Given this list of marker genes ATP2B1, YPEL2, PLPP1, STING1, HIF1A, CNIH4, ISCU, LMNTD2, SNRNP70, CLINT1, LSM14A, SRCAP, ST6GALNAC2, CACNG4, FRYL, MYO1E, DGAT1, SLC43A1, ARID1B, ANGPTL2, GNB5, BRD9, FAM151B, CLEC4G, GRIN2B, CERS5, COX7A1, TAF8, ELL, MAP4K3, IGF1R, ZFR2, RGS1, ITGA4, GMIP, PLA2G3, ACAP2, MICALL1, BCL2A1, NOXRED1, ESYT2, C5orf34, SLAMF1 (NCBI Gene Id 6504), TNFRSF9, RASL11A (RAS like family 11 member A), ZNF362, FBLIM1, CCDC125, DDI2, ENTPD7, C19orf81, TNFRSF1B, SCLY, CDH7, GDNF, ITGB3, GAS8, SSBP3, RNPEPL1, ZBTB7B, NUCB2, PRNP, BIRC3, PPM1L, CORO2A, INPP4A, NEDD9, CTDSP2, PSEN2, PTTG1, FOXK2, FBXO6, IFI30 (IFI30 lysosomal thiol reductase), TMIGD1, TECPR1, BCR, CIR1, ECM1, TNFRSF25, FAM234B, SLC33A1, ITGAV, PGM5, CAPSL, GPX4, RAB37, WASF3, TMBIM4, EBI3, PADI4, LYZL6, CBLN3, PRDX5, IWS1, TSC22D1, ICOS, SLC12A6, PGGHG, KIFC1, PCDHB4, KDM2B, ADGRE5, ARPC2, STARD5, TIAM1, STMN1, MSL2, VPS54, ARHGAP31, SECISBP2L, NDST1, MTMR7, IDS, CCDC82 (NCBI Gene Id 79780), NID2, NRN1 (neuritin 1), EPHX4, RTN4, TNFRSF18, SUCO, THBD, ELP2, PHF3, HNRNPLL, TSPAN13, MFAP1, CWC15, C11orf96, SNX20, RAB22A, RBL2, CD6, DROSHA, MAP1LC3B, DND1, PRR13, CNTLN, TRIM46, CDKN2C, MLLT6, FERMT3, PLSCR1, SLC9A6, CPM, TEX2, C4BPA, CASP1, EXT1, NRDC, GTPBP2, IL17B, CDC25B, NHSL2, ATP11A, SPOP, NCK2, IBSP, CYSTM1, CPOX, ZDHHC15, CREBBP, SLC4A7, CHURC1, PLPP5, PTGER2 (prostaglandin E receptor 2), ZNF326, ODAM, DCAF11, SLC2A3, H1-0, DYNC1I2, KIAA0753, GAS2L1, TMEM191C, MYO5A, LRP10, ZNF462, APBA1, MKNK2, GXYLT1, RHBDF1, RAB2A, KCTD10, P2RX7, SON, FAAH, SZT2, WTAP, RNF19A, UROS, PISD, CASP4, ZMYND8, MAP2, CELA1 (NCBI Gene Id 1990), NEURL4, TMUB1 (transmembrane and ubiquitin like domain containing 1), GCA, CATSPERD, SSR1, here is a description of the gene set: Human Gene Set: GSE27786_CD4_VS_CD8_TCELL_UP species: Homo sapiens Genes up-regulated in comparison of CD4 T cells versus CD8 T cells. Each fraction of mouse hematopoietic cells was purified by cell sorting from bone marrow of 8-week-old C57BL/6 mice, and its gene expression was analyzed. from publication Konuma T, Nakamura S, Miyagi S, Negishi M, Chiba T, Oguro H, Yuan J, Mochizuki-Kashio M, Ichikawa H, Miyoshi H, Vidal M, Iwama A (PMID 21540074)